The following is a description of a gene set: Genes predicted to be targets of miRBase v22 microRNA mmu_miR_377_5p in miRDB v6.0 with MirTarget v4 prediction scores > 80 (high confidence targets). species: Mus musculus from publication Chen Y, Wang X (PMID 31504780) Mouse Gene Set: MIR_377_5P, and this is the list of marker genes: Trio, Acbd5, Ifnlr1, Kif2c, Cd200r3, Plin5, Krt6b, Klf12, Aim2, Clec7a, Angptl4, Gpr22, Pde4a, Zfp446, Ank1, Rad51d, Irf9, H2-M10.3, Clec12a, Cdh10, Glb1l2, Tmem167, Rpap2, Krtap8-1, Syt11, Ago1, Fkbp1a, Adgrb3, Trib1, Kcnh1, H2-M10.5, Tmem106b, Cfb, Cyp2g1, Itga9, Msl2, Tgfa, Osbpl1a, Nup98